The following is a description of a gene set: Genes predicted to be targets of miRBase v22 microRNA hsa-miR-4453 in miRDB v6.0 with MirTarget v4 prediction scores > 80 (high confidence targets). studied in species Homo sapiens Human Gene Set: MIR4453 from publication Chen Y, Wang X (PMID 31504780), and this is the list of marker genes: E2F3, RELN, AZIN1, CCT6A, FNDC3B, PDCD6IP, CCDC179, RPGR, GRIA3, SUB1, ZNF761, BHLHE40, PRX, RPF2, LRFN3, SLC7A14, ARPC2, GK5 (glycerol kinase 5), PLPP3, RERE, TTN, ZBTB7B, TMEM117, PPP4R4, WDR26, ASB4 (ankyrin repeat and SOCS box containing 4), LRRC55